The following is a description of a gene set: Mouse Gene Set: GOCC_AMPHISOME_MEMBRANE studied in species Mus musculus Any membrane that is part of an amphisome., and this is the list of marker genes: Chmp2b, Chmp1a, Chmp3, Chmp1b2, Chmp1b, Chmp7, Chmp6, Chmp4c, Chmp2a, Chmp4b, Chmp5